The following is a description of a gene set: GABA B receptors are metabotropic receptors that are functionally linked to C type G protein coupled receptors.? GABA B receptors are activated upon ligand binding. The GABA B1 subunit binds ligand and GABA B2 subunit modulates the activity of adenylate cyclase via the intracellular loop.? GABA B receptors show inhibitory activity via Galpha/G0 subunits via the inhibition of adenylate cyclase or via the activity of Gbeta/gamma subunits that mediate the inhibition of voltage gated Ca2+ channels. species: Homo sapiens Reactome Pathway: Activation of GABAB receptors part of: GABA B receptor activation, and this is the list of marker genes: GNAI1, GNG3, KCNJ2, GNB3, KCNJ4, ADCY5, GNAI2, KCNJ10, GNAL, KCNJ16, ADCY2, KCNJ5, GABBR2, GNAI3, GNAT3, GNGT1, GNG4, GNG11, ADCY3, GNB4, KCNJ3, ADCY1, GNB2, ADCY6, ADCY4, KCNJ15, KCNJ9, GNGT2, ADCY9, ADCY8, ADCY7, GNB5, GNG2, GABBR1, GNG5, KCNJ6, GNG10, GNG8, GNG13, GNG12, GNG7, GNB1, KCNJ12